The following is a description of a gene set: Mouse Gene Set: REACTOME_METALLOPROTEASE_DUBS studied in species Mus musculus Metalloprotease DUBs, and this is the list of marker genes: H2ac23, H2ac15, Babam1, H2ac20, Kat2b, Babam2, Uimc1, H2ac19, Stambpl1, H2ac12 (NCBI Gene Id 319168), Uba52rt, Ubc (NCBI Gene Id 77003), Brcc3, H2ac10, Uba52, H2aj, H2ac6, H2ac8, Brca1, H2ac1, H2ac13, H2ac22, H2ac18, H2ac7, Rps27a, Abraxas2 (BRISC complex subunit), Mysm1, Psmd14, H2ac21, Ep300, Ubb, H2ac11, Bard1, Nlrp3, Stambp, H2ac25, H2ac24, Abraxas1, H2ac4, Stam